The following is a description of a gene set: The chemical reactions and pathways resulting in the breakdown of imidazoles, five-membered organic heterocycle containing two nitrogen atoms at positions 1 and 3, or any of its derivatives; compounds containing an imidazole skeleton. Mouse Gene Set: GOBP_IMIDAZOLE_CONTAINING_COMPOUND_CATABOLIC_PROCESS species: Mus musculus, and this is the list of marker genes: Amdhd1, Hdc, Hnmt, Uroc1, Ftcd, Hal